The following is a description of a gene set: The directed movement of poly(A)+ mRNA out of the nucleus into the cytoplasm. Mouse Gene Set: GOBP_POLY_A_PLUS_MRNA_EXPORT_FROM_NUCLEUS studied in species Mus musculus, and this is the list of marker genes: Iws1, Pcid2, Nxt1, Pabpn1, Poldip3, Nxf3, Eny2, Thoc2l, Gle1, 1700017N19Rik, Nxf7, Ddx19a, Zc3h11a, Nup133, Hhex, Mcm3ap, Ddx19b, Nxf2, Sarnp, Nxt2, Nxf1, Thoc2, Nup93, Ddx25